The following is a description of a gene set: Mouse genes annotated to increased carcinoma incidence (MP:0002038) retrieved from the Mouse Genome Informatics database via MouseMine studied in species Mus musculus Mouse Gene Set: MP_INCREASED_CARCINOMA_INCIDENCE from publication Motenko H, Neuhauser SB, O'Keefe M, Richardson JE (PMID 26092688), and this is the list of marker genes: Trp73 (transformation related protein 73), Men1, Rev3l, Apc, B3gnt6, Pik3ca, Mlh1, Tlr2, Apex1, Cdkn2a, Prdx1, Htatip2, Braf, Rb1, Sptbn1, Kras, Sav1, Stat3, Cbx7, Raph1, Paqr3, Tff1, Chuk, Hic1, Akt1, Lzts1, Nf2, Stag1, Trim37, Cdkn1a, Fancd2, Pms2, Tes, Brca2, Smad4, Ssbp2, Mad1l1, Pten, Pinx1, Errfi1, Tmem207, Robo1, Trp53, Mus81 (NCBI Gene Id 71711), Tnk1